Given this list of marker genes ZC3H11A, DCAF5, KLF3, FLRT1 (fibronectin leucine rich transmembrane protein 1), CCDC82, PID1 (phosphotyrosine interaction domain containing 1), RHEB, MTF1, ATP1B4, NAV3, YIPF4, RHOQ, ZC3H12A, CLN8, ZNF189, HEATR5B, RTKN2, CNTN2, B4GALNT1, SNU13, PPTC7, TFCP2L1, YAF2, LIX1, NPAS3, MFSD6, MXI1, INSM2, MAPKAPK3, NUDT12, TRAF1, BNC2, SOX30, DYRK1A, DNAJC3, PAK6, C9orf43, NRP2, here is a description of the gene set: from publication Chen Y, Wang X (PMID 31504780) Human Gene Set: MIR4750_3P species: Homo sapiens Genes predicted to be targets of miRBase v22 microRNA hsa-miR-4750-3p in miRDB v6.0 with MirTarget v4 prediction scores > 80 (high confidence targets).